Given this list of marker genes ABCA12, FAM76B, BNIP3L, EPB41L5, HPCA, OOEP, HCLS1 (NCBI Gene Id 3059), STX4, FGA, RFX3, F2R, GAPVD1, MAPT, UBE2J2, EFCAB7, DMAP1, SLC51B, INS, MIR19B1, ADRA2A, NR1H2, GLUD1, GIPR, CCL5, MDM2, RAPGEF4, RAP1GDS1, BAG4, PFKFB2, CIB1, FGB, UMOD, ITGAM, OPRM1, IL1B, BMAL1, WWP2 (NCBI Gene Id 116013), VPS28, RHOU, BMP8A, SSTR5, UBL5, PRKACA, F2RL1, PICK1, CCT6A, EDEM1, MIR766 (microRNA 766), RAB11FIP5, PRR5L, GSK3A, TCAF2, PFKM, CEP295, ZBED6, CWH43, SIRT7, LYPLA1, ITGB2, SIAH3, TRPM5, HNF4A, MICALL2, PTPN23, ANKRD1, INHBB, ZDHHC2, CAPN10, HSPA8, DYNLL1, SH3TC2, ANXA13, ZC3H12A, SYTL4, GCC2, MIR128-1, P3H1, NEO1, CEP135, EFNA5, APP, MCU, FOXO1, FUT10, TMEM30B, TCF7L2, TERF1, PPID, UBE2J1, NSD2 (NCBI Gene Id 7468), NR1H4, TMEM97, LCP1, ABAT, RAB8A, GIP, CEP131, CAMK1, MPC2, SLC25A22, CSK, NNAT, CD81, PRKD1, ATG13, NUP58, TTN, IL6, ZFAND1, GCK, MIR146A, MAPK8, FRAT1, CRH, SNX3 (NCBI Gene Id 8724), PDE8B, CD36, TOMM70, CABP1, UCP2, HSP90AA1, UBE2D3, IRS2, ACSL3, HADH, PARL, PIK3R1, CDK5R1, JAK2, HCAR2 (NCBI Gene Id 338442), CHP2 (NCBI Gene Id 63928), ECT2, ERGIC3 (NCBI Gene Id 51614), IFNG, LEP, PDZK1, TARDBP, GPLD1, BCAP31, PPM1A, CLN3, VPS35, ERBB2, FBXW7, CTDSPL2 (NCBI Gene Id 51496), CYP51A1, NDUFAF2, SLC30A8, IFI27, SLC9B2, EI24, MIR29B1 (NCBI Gene Id 407024), PTPN11, C2CD5, HMGCR, JUP, SIRT4, SP100, NR1D1, RIPOR1, SLC12A2, GHRL, MIR199A1, TFAP2B, TENM1, CORO2B, LEPROT, STX1A, ADIPOQ, IDH2, IL12B, MIR148A, YWHAB, EPM2A, MYOM1, DNAJC1, TRIM28, ATP2C1, MIR93, BRSK2, MIEF1, SIDT2, EPHA5, VPS11, TGFB3, PFKL, FRMD4A, GRIPAP1, OAZ1, F2RL2, UBL4B, AKAP5, CFTR, UBR5, FOXA2, ZIC1, EDEM2, TNF, DOC2B, PIM3, ACHE, LRRC8A, EP300, GNAI1, PLA2G1B, ARHGEF5, JAGN1, APBB1, PRKN, RAB11A, RHBDD3, PDX1, CRYZL2P-SEC16B, EIPR1, SIRT3, APOD, RAPGEF3, IGF1, ARF6, CDKN2A, PLK3, SMAD3, TXN, CTSD, SEC16B, SLC7A11 (NCBI Gene Id 23657), INSIG1, RBM22, SLC1A1, MIEF2, TRPM4, WRAP53, SNX12, CSNK2A2, CD200, STXBP4, C11orf65, FFAR2, GPR27, FZD5, SMO, SNAP25, GNAZ, NR1H3, HUWE1, PCNT, SIRT6 (sirtuin 6), VEGFC, CHP1, UBE2G2, FLNA, HDAC6, P2RX7, NDEL1, MAVS, ANGPT1, CEP120, SFN, CEMIP, NF1, TCAF1, BBC3, PPP3CB, G6PC2, ZPR1, PSEN1, CPT1A, REST, SOX4, ERLEC1, ADTRP, ATP5IF1, TGFB1, PAK1, UBAC2, SLC16A1, CENPJ, ANO1, SH3GLB1, GPR68, C2CD2L, FAM3D, COMMD1, RUFY3, TM9SF4, F2, XPO1, MTCL1, DRD2, KCNJ11, CHRM1, SERP1, NOS2, MDFIC, OR51E2, ENY2, UHMK1, SEPTIN8, PDCD10, SERGEF, FUT11 (NCBI Gene Id 170384), RSC1A1, NMT1, GAS6, ALOX5, GOLPH3L, ERP29, ANK3, INPP5K, ACVR1C, FYN, PHPT1, ACSL4, ANP32B, SUFU, USP17L2, TOMM7, CEP290, CCN3, ITGB1BP1, ANG, ABCG1, GPER1, RAC1, PTPN1, NPEPPS, PRNP, IL13, BARD1, NLGN2, TCIRG1, MLXIPL, MIR199B, C1QTNF3, VAMP2, RAB23, ABLIM3, PKDCC (protein kinase domain containing, cytoplasmic), ADAM8, CDH1, FGG, CLOCK, FKBP1B, PARD6A, SELENOK, ARIH2 (ariadne RBR E3 ubiquitin protein ligase 2), RHBDF1, RANGAP1, KCNB1, CD2AP, NMU, EMD, MYO1C, RAN, PCM1, KIF20B (kinesin family member 20B), SEC24A, GSK3B, OAZ3, KRT20, SLC2A2, ATP13A2, RACK1, CNST, C1QTNF12, IER3IP1, FERMT1, OS9, RAC2 (NCBI Gene Id 5880), PRKCB, SREBF1, NEUROD1, ISL1, USP36, ADCY10, TMEM30A, IPO5, GNAO1, IL1A, AKT2, YWHAE, KCNE1, YOD1, PRKCD, STOM, ASPH, PRKAA1, BAP1, OSBP, BMP4, NKX6-1, UFM1, GPRC6A, MIDN, RSAD2 (NCBI Gene Id 91543), CDK1 (cyclin dependent kinase 1), NFKBIA, TMEM132A, MYO18A, PPARG, HPS4, ARFIP1, CHGA, ITPR1, XBP1, UBE2L3, HSPA1L (NCBI Gene Id 3305), HLA-DRB1, LRRK2, GNAS, SPIDR, GCG, TSG101, VAMP4, WLS (Wnt ligand secretion mediator), PCK2, SYT4, CELA2A, SUMO1, DERL3, RAB11FIP1, NDFIP2, CARTPT, GJA5, GLI3, TUNAR, TRPA1, BAD, ADRA2C, KCNA5, GZMB (granzyme B), TCP1, ADCY8, MYH10 (NCBI Gene Id 4628), PKIG, PLA2G6, CHRM3, DPH3, MTNR1B, CASR, MIR30C1, MAPK14, HDAC3, PSMD9, NR0B2, ARHGAP44, HYAL2, BMP6, PRP4K, BSG, SRI, FRAT2, RHBDF2, ACD, NDFIP1, AACS, KIAA0586, ADAM9, PER2, HRAS, DNAJA1, FFAR1, TLR4, SAA1, ORAI1, SHH, KCNK16, PPARD, RNF31, CD38, IL12A, HIF1A, USP7, TRH, ENSA, HAX1, VSNL1, LRP5, UCN3, ICE1, PRKCE, TGFB2, TMED10, SORL1 (NCBI Gene Id 6653), PRKAR1A, BLK, APBB3, ABCC8, LYPLAL1, LMAN1, SLC8B1 (NCBI Gene Id 80024), OAZ2, UNC13B, BAG3, PIK3R2, TLR2, B3GAT3, UQCC2, IRS1, PINK1, CDK5, MYRIP, DRD4 (NCBI Gene Id 1815), RAB29, GNA11, PTP4A3 (NCBI Gene Id 11156), BAIAP3, MIR19A, SAE1, PPM1F, RAB11FIP3, PPIA, PLCB1, GDI1, NADK, XPO4, GHSR, RPH3AL, PGRMC1, SLC35D3, DERL2, SYBU (syntabulin), CD33, SVIP, HTRA2, RFX6, PTPN14, PRKCA, RBP4, TPR, TM7SF3, ADORA2A, GOLPH3 (golgi phosphoprotein 3), DRD3, CDK16, KCNN4, SREBF2, SYT7, EXPH5, CPLX1, KLF7, DNM1L, OXCT1, PARK7, APOE, ADCY5, PKIA, TREM2, SCFD1, DMTN, NPFF, here is a description of the gene set: Human Gene Set: GOBP_REGULATION_OF_ESTABLISHMENT_OF_PROTEIN_LOCALIZATION species: Homo sapiens Any process that modulates the frequency, rate or extent of the directed movement of a protein to a specific location.